The following is a description of a gene set: The process whose specific outcome is the progression of the metanephric proximal tubule over time, from its formation to the mature structure. The metanephric proximal tubule is a metanephric nephron tubule that connects Bowman's capsule to the descending thin limb of the loop of Henle in the metanephros. It has a brush border epithelial morphology. species: Homo sapiens Human Gene Set: GOBP_METANEPHRIC_PROXIMAL_TUBULE_DEVELOPMENT, and this is the list of marker genes: PKD1, ACAT1, SLC22A1, SLC22A6, AQP1